The following is a description of a gene set: CD4 T cell help is critical for both the generation and maintenance of germinal centers, and T follicular helper (TFH) cells are the CD4 T cell subset required for this process. SAP (SH2D1A) expression in CD4 T cells is essential for germinal center development. However, SAP-deficient mice have only a moderate defect in TFH differentiation as defined by common TFH surface markers. CXCR5+ TFH cells are found within the germinal center as well as along the boundary regions of T/B cell zones. Here we show that germinal center associated T cells (GC TFH) can be identified by their co-expression of CXCR5 and the GL7 epitope, allowing for phenotypic and functional analysis of TFH and GC TFH populations. Here we show GC TFH are a functionally discrete subset of further polarized TFH cells, with enhanced B cell help capacity and a specialized ability to produce IL-4 in a TH2-independent manner. Strikingly, SAP-deficient mice have an absence of the GC TFH subset and SAP- TFH are defective in IL-4 and IL-21 production. We further demonstrate that SLAM (Slamf1, CD150), a surface receptor that utilizes SAP signaling, is specifically required for IL-4 production by GC TFH. GC TFH cells require IL-4 and IL-21 production for optimal help to B cells. These data illustrate complexities of SAP-dependent SLAM family receptor signaling, revealing a prominent role for SLAM receptor ligation in IL-4 production by germinal center CD4 T cells but not in TFH and GC TFH differentiation. Human Gene Set: GSE21379_WT_VS_SAP_KO_TFH_CD4_TCELL_UP from publication Yusuf I, Kageyama R, Monticelli L, Johnston RJ, Ditoro D, Hansen K, Barnett B, Crotty S (PMID 20525889) Genes up-regulated in CD4 follicular helper T cells (Tfh) with SH2D1A knockout versus wildtype Tfh cells. studied in species Homo sapiens, and this is the list of marker genes: BOK, LHFPL6, MAF, MPZL1, SMDT1, LCN2, EXOC3L1, DMKN, C3, ZNF697, FCGR3A, PALLD, RIN1 (NCBI Gene Id 9610), KHK, SCAMP5, ZFP37, ECSCR, COL4A1 (NCBI Gene Id 1282), RAPH1, TMEM204, LIMA1, GCHFR, SLC7A8, GPX8, CXCR3, AXL, OPHN1, SCARF1, NHSL2, FKBP9, PAK6, SH3RF2, SPIN4, SLC4A3, SH3D19, CAMK2A, NREP, GSTM1, SHISA2, DOCK5, PIANP, DLC1, CLEC11A, TIE1, RALB (NCBI Gene Id 5899), TMEM170A, GSTT1, GPT2, NRP2, PROM1, MCUB, TEAD2, SIK2, CTNND1, CD38, P3H3, CYP27A1, TMC4, PXDN, RHOJ, ESAM, ZNF385A, KRT80, SELP, ADCY4, RAB34, SERPINH1, FAH, GIMAP4, CCNYL1, SHROOM4, THY1, LHPP, ICAM2, DOCK1, EVC2, DGAT2, AK1, CYB561, LDB2, BMP2K, ZNF410, ABCC3 (NCBI Gene Id 8714), TLCD3A, SEM1, ARPIN, FGD5, USP54, TFPI, WIF1, COQ6 (NCBI Gene Id 51004), RAB13, MAPK13, ITGB3, CD200R1L, DOCK6, FGFR1, CLSTN3, NRP1 (neuropilin 1), CDC42BPB, TTC23, SGK1, MRC1, DAB2, PTGS1, CBR3, PWWP3B, ATP5F1E (NCBI Gene Id 514), ICA1, RND3, CDH5, PTPRK, SMPDL3B, GALC, ATG9B, LRG1, GHR (growth hormone receptor), SOX18, SELENOM, NHERF2, COL4A2, TEK, GNG11 (G protein subunit gamma 11), MS4A3, TMEM119, C1R, ERP27, XDH, F5, FHL1, CARD10, IGSF6, HOXB2, APLNR, STAP2, GBX2, FCGR2A, FSCN1, EXOC3L4, BGN, TIGD5, TLE6, ARHGAP29, AP2S1, MTUS1, TSLP, NEK5, MYOM1, IL1RL2 (interleukin 1 receptor like 2), CCDC120 (coiled-coil domain containing 120), S100A1, RND2, CC2D2A, KRT18, AJUBA, USP2, H1-0, TNFAIP8L1, GNS, TGM1, TM4SF1, RAB3IL1, CELF5, FRK, ASAP2, CD14, DSG2, DUSP9, FUOM, DIRAS2, FAM167B, F2RL2, TMEM132A, PDE9A, KDR, MYO1E, TRIP6, SPATS2, CCDC85B, DLK1, SPA17 (sperm autoantigenic protein 17), TCF15, SLC7A2, ADGRA2, GUCA1A, FKBP1B (FKBP prolyl isomerase 1B), LAMB2, CLU, BHLHE40, DKKL1, GPR4, VAMP8, KANK3, F2R, AKAP12, CD302, RASGEF1B, NPDC1 (neural proliferation, differentiation and control 1), MEG3, IFT43